Given this list of marker genes SLC39A8, SLC39A4, MMP1, SLC7A7, COL7A1, PSTPIP1 (NCBI Gene Id 9250), IARS1, SLC30A2, here is a description of the gene set: Abnormal blood zinc concentration Human Gene Set: HP_ABNORMAL_BLOOD_ZINC_CONCENTRATION studied in species Homo sapiens An abnormality of zinc ion homeostasis.